Given this list of marker genes KCNJ14, KCNJ12, KCNJ2, KCNJ4, here is a description of the gene set: Reactome Pathway: Classical Kir channels studied in species Homo sapiens part of: Inwardly rectifying K+ channels Classical Kir channels are inwardly rectifying K+ channels with strong inwardly rectifying currents that contribute to highly negative resting membrane potential, prolonged action potential plateau and rapid repolarization in the final stage of action potential. Classical Kir channels are found in various cells such as cardiac myocytes, purkinje fibers, atrial and ventricular tissues. Rectification is caused by intracellular Mg2+ ions and polyamines.